The following is a description of a gene set: studied in species Homo sapiens from publication Cui Y, Zheng Y, Liu X, Yan L, Fan X, Yong J, Hu Y, Dong J, Li Q, Wu X, Gao S, Li J, Wen L, Qiao J, Tang F (PMID 30759401) Human Gene Set: CUI_DEVELOPING_HEART_CARDIAC_FIBROBLASTS, and this is the list of marker genes: GAPDH, SOX9, CRIP2, CSRP3, TCF21, SYNPO2L, RRAD, MYBPC3, PLN, MYL4, LAMC1, SMYD1, ACTC1, FGF12, FREM1, PTN, SMPX, MDH1, COL9A1, NEBL, PGAM2, MYL3, IGFBP2, HSPB7, TNNI1 (NCBI Gene Id 7135), RAMP1, SH3RF2 (NCBI Gene Id 153769), ATP5MC2 (ATP synthase membrane subunit c locus 2), BNIP3, ENO3, TRIL, PDLIM5 (PDZ and LIM domain 5), FRZB, ANKRD1, TNNC1, PPP1R3C, CRYAB, TTN (titin), MYL7, AKR1B1, COLEC11, TNNT2 (NCBI Gene Id 7139), ALDH1A2, MYOZ2, COX6A2, TCAP, LRRC10, NMRK2, NPPA, COX5A, ACTN2, MYH7, TM4SF1, MOXD1, CKM, CCND1, MYH6, PKIG, PEG3, SCN7A, TFPI, ENG, LDB3, DES, FHL2, ATP2A2, FABP3, LAMB1, NEGR1, SH3BGR, CKMT2, MB, TPM1, FITM1, TNNI3, BANCR, RBM24, LOXL2, CCDC102B, MYL9, GASK1B, IL32, ALDOA, NKX2-5, SLC25A4, MYOM1, COL6A3, NPPB, LIMCH1, C7, HSPB1, SORBS2, RBPMS2, COL15A1, RYR2, COX7B, TRDN, MYL2, GOT1, CASQ2, HSPB3, HACD1, ALDOC, CSRP1, PKM, S100A8